The following is a description of a gene set: species: Homo sapiens Genes down-regulated in the epithelial-mesenchymal transition (EMT) upon transforming growth factor beta (TGFb) stimulation derived from multiple datasets using a product of ranks meta-analysis approach. Human Gene Set: FOROUTAN_PRODRANK_TGFB_EMT_DN from publication Foroutan M, Cursons J, Hediyeh-Zadeh S, Thompson EW, Davis MJ (PMID 28119430) Most cancer deaths are due to metastasis, and epithelial-to-mesenchymal transition (EMT) plays a central role in driving cancer cell metastasis. EMT is induced by different stimuli, leading to different signaling patterns and therapeutic responses. TGF_ is one of the best-studied drivers of EMT, and many drugs are available to target this signaling pathway. A comprehensive bioinformatics approach was employed to derive a signature for TGF_-induced EMT which can be used to score TGF_-driven EMT in cells and clinical specimens. Multiple datasets were used to derive the signature using three approaches: by integrating the datasets prior to identifying EMT genes, by first identifying EMT genes from individual datasets and then combining them using a meta-analysis (product of ranks) approach, and by combining inferences from the first two approaches., and this is the list of marker genes: C1orf115, CITED2, GLDC (glycine decarboxylase), JAG2, PLS1, PLAAT4, SLCO4A1, SLC16A7, MBP, S100P, EHF, KITLG, GSE1, GDF15, TJP2, TBC1D8, HPGD, RAB38, CXADR, SYBU, ANK3, CYB5A, NUP210, MAP7, ERBB3, DEPTOR, SORD, SULT1A1, MTUS1, EPAS1, MMP7, TNFAIP2, PKP2, RAB26, DST, IMPA2, ABLIM1, ESRP1 (epithelial splicing regulatory protein 1), ELF3, EPB41L4B, CEBPD, MITF, SQOR, HOOK1, CYP1B1, BIRC3, AREG, SCNN1A, ERMP1 (endoplasmic reticulum metallopeptidase 1), PPP1R9A, NR2F2, TPD52L1, EREG, GULP1, ALDH3A2 (NCBI Gene Id 224), ALDH5A1, C1orf116, TMT1A, ARHGAP29, FOXA2, SLC27A2, ADORA2B, MUC1, LY6E, SPRY1 (NCBI Gene Id 91129), PDK4, CD9, MYO5C, EPCAM, SERPINB1, LAMA5, GPRC5C, TFAP2A, PPL, SMPDL3B, KRT19, CAVIN2, CDH1, AGR2, PLAAT3, RBM47 (NCBI Gene Id 54502), PEG10